The following is a description of a gene set: Genes predicted to be targets of miRBase v22 microRNA hsa-miR-4793-3p in miRDB v6.0 with MirTarget v4 prediction scores > 80 (high confidence targets). species: Homo sapiens Human Gene Set: MIR4793_3P from publication Chen Y, Wang X (PMID 31504780), and this is the list of marker genes: CHMP2B, SREK1IP1, RNF169, GABRA1, SMAP1, RNF125, ADGRE2, MXI1, ATP2A2, ZIC1 (Zic family member 1), ETV5, NKAIN2, EXT1, PRKG1, RDH11, TENM4, LMNB1, CEP44, MAP3K20, PDS5A, MEAF6, PAPOLG, PRRC2B, ATP8A2, EHMT1, GATAD2A, TIAM2, MAP4K4, MINPP1, DISC1, DTNA, C3orf52, BTBD3, SNX18, TTC14, ZNF658, SOX11, ANK2, WDR1, EFR3A, SNX3, CSF1, SSR1, BICD2 (NCBI Gene Id 23299), ZNF93, TRIP11, ZNF471, BCCIP, CANX, SERTM1, VPS36, KPNA3, FAM217B, SDK1, CLCN3, ZFAND6 (zinc finger AN1-type containing 6), SESN3, CAMSAP2, ISOC1, RAPGEF2, CSDE1, TMEM255A, FNDC3A, RPRD1A, MAP3K1, RNF103, NUP214, SOWAHC, LIN9, KBTBD11, SPIN1